Given this list of marker genes Itgb3, Fgg, Gp1ba, Fbln1, Mvp, Fga, F13a1, Fgb, Prcp, Apoh, F8, F2 (coagulation factor II), Gp9, Klk1b1, Rasal2, Gp1bb, F12, Gp5, Flna, F13b, Pdia4, here is a description of the gene set: A sequential series of modifications to a set of proteins where the product of one reaction catalyzes the following reaction, ultimately leading to the generation of a mature protein. Modifications typically include proteolysis or covalent modification, and may also include binding events. Mouse Gene Set: GOBP_PROTEIN_ACTIVATION_CASCADE studied in species Mus musculus